The following is a description of a gene set: Human Gene Set: GOBP_POSITIVE_REGULATION_OF_MITOCHONDRIAL_CALCIUM_ION_CONCENTRATION species: Homo sapiens Any process that increases the concentration of calcium ions in mitochondria., and this is the list of marker genes: MICU2, MICU1, MCU, SLC25A23, MCUR1, ATP2A1, TGM2, RAP1GDS1, BNIP3